The following is a description of a gene set: Human Gene Set: GOBP_PENTOSE_PHOSPHATE_SHUNT_NON_OXIDATIVE_BRANCH The branch of the pentose-phosphate shunt which does not involve oxidation reactions. It comprises a series of sugar phosphate interconversions, starting with ribulose 5-P and producing fructose 6-P and glyceraldehyde 3-P. studied in species Homo sapiens, and this is the list of marker genes: RPEL1, RPIA, SHPK, TKT, RPE, TALDO1